The following is a description of a gene set: studied in species Mus musculus Genes predicted to be targets of miRBase v22 microRNA mmu_miR_5106 in miRDB v6.0 with MirTarget v4 prediction scores > 80 (high confidence targets). Mouse Gene Set: MIR_5106 from publication Chen Y, Wang X (PMID 31504780), and this is the list of marker genes: Egfr, 2810021J22Rik, Cend1, Wdr64, Rad21, Rp1, Nfia, Alg11, Xirp1 (NCBI Gene Id 22437), Ubiad1, Golga5, Clip3, Clcc1, Bicd2, Kdm3a, Mllt3, Ube2z, Ano5, Ndrg1, Poln, Fam210a, Zfpm2, Rhoj, Rab30, Mtf2, Igsf21, Sox11, 4930486L24Rik, Tmem178, Camk1d, Zfp213, Chd2, Tanc2, Ube2q1, Acbd6, Stt3b, Gja8, Glis1, Cthrc1, Slc17a6, Gm17455, Rab7, Lcmt2